Given this list of marker genes ADAM19, FOXA1, NOTCH1, WNT3A (NCBI Gene Id 89780), PLG, AFDN, EPCAM, WNT5A, SMAD7, TGFB1, BMP6, SERPINF2, VEGFA, FOXA2, MAD2L2 (NCBI Gene Id 10459), NOTCH4, TJP1, DENND6A, NEXMIF, FLOT1, RGCC, PTPRU, PPM1F, here is a description of the gene set: Human Gene Set: GOBP_REGULATION_OF_CELL_CELL_ADHESION_MEDIATED_BY_CADHERIN Any process that modulates the frequency, rate or extent of cell-cell adhesion mediated by cadherin. studied in species Homo sapiens